The following is a description of a gene set: MicroRNAs (miRNAs) are 19 to 23 nucleotide-long RNAs that post-transcriptionally regulate gene expression. Human cells express several hundred miRNAs which regulate important biological pathways such as development, proliferation, and apoptosis. Recently, 12 miRNA genes have been identified within the genome of Kaposi sarcoma-associated herpesvirus; however, their functions are still unknown. To identify host cellular genes that may be targeted by these novel viral regulators, we performed gene expression profiling in cells stably expressing KSHV-encoded miRNAs. Data analysis revealed a set of genes whose expression was significantly changed in the presence of miRNAs. While the majority of changes were below 2-fold, eight genes were down-regulated between 4- and 20-fold. We confirmed miRNA-dependent regulation for three of these genes and found that protein levels of thrombospondin 1 (THBS1) were decreased >10-fold. THBS1 has previously been reported to be down-regulated in Kaposi sarcoma lesions and has known activity as a strong tumor suppressor and anti-angiogenic factor, exerting its anti-angiogenic effect in part by activating the latent form of TGF-beta. We show that reduced THBS1 expression in the presence of viral miRNAs translates into decreased TGF-beta activity. These data suggest that KSHV-encoded miRNAs may contribute directly to pathogenesis by down-regulation of THBS1, a major regulator of cell adhesion, migration, and angiogenesis. from publication Samols MA, Skalsky RL, Maldonado AM, Riva A, Lopez MC, Baker HV, Renne R (PMID 17500590) species: Homo sapiens Human Gene Set: SAMOLS_TARGETS_OF_KHSV_MIRNAS_DN Genes down-regulated in 293 cells (embryonic kidney) upon expression of KHSV (Kaposi sarcoma-associated herpesvirus) microRNAs., and this is the list of marker genes: UCHL1, SLC1A4, SPOCK3, SPINT2, CDC16, THBS1, STAT1, MID1IP1, LDLRAD4, DNAJC12, VPS37C, CRY1, IFI16, FGF13, LZTS1, PDZK1, FZD10, SLC44A5, PUDP, ANXA4, HTATIP2, IRS1, ITM2A, FN1, CFI, HSPA1A, IL13RA1, PLAC8, C11orf58, PRXL2A, NXPH4, PMEPA1, SLC6A15, UCP2, EPCAM (NCBI Gene Id 4275), LDOC1 (LDOC1 regulator of NFKB signaling), FKBP11, AKR1C3, EPAS1, MAGEH1, PNMA8A, ARMCX6, INHBA, LINC00115, SRGN, TBPL1, SHISA2, PLIN2, CD44, CXXC5, BHLHE22, MAOA, FHL2, RAB27A, STAT3, DKK3, SPP1, TPD52, HAVCR1, S100A2